Given this list of marker genes Plgrkt, Slc9a9, Cdnf, Pcdh11x, Garin1a, Mtmr7, Oas1f, Mtf1, Mlxip, Lepr, Capza1, Gramd4, Slc6a8, Sema6d, Nova2, Hmg20a, D630039A03Rik, Gm14461, Fmo9, Srcap, Gpr141b, Rrp7a, Zfp518b, Fbxl7, Dnaaf5, Rps6ka4, Ptk2, Onecut2, Pknox2, Gnal, Cdv3, Zfp458, Hdac2, Dhfr, Ccndbp1, Kics2, Crebrf, P2ry1, Plxna4, Scn2a, Mertk (NCBI Gene Id 17289), Primpol, Bloc1s5, Hectd1, Plxna2, Cfap44, Zfp827, Rap1b, Lrrc75a, Hhla1, Ppp4r3b, here is a description of the gene set: Genes predicted to be targets of miRBase v22 microRNA mmu_miR_6934_5p in miRDB v6.0 with MirTarget v4 prediction scores > 80 (high confidence targets). Mouse Gene Set: MIR_6934_5P species: Mus musculus from publication Chen Y, Wang X (PMID 31504780)